Given this list of marker genes AP4E1, SYT2, LSM12, SCYL1, RPGR, ARHGAP26, PNKD, OPRL1, TSPAN11, SLC31A1, M1AP, NCL, ADCY1, SLCO3A1, KCNJ5, STARD3, SRRM1, DLGAP1, HTT, HIBADH, BCL2L2, DGKG, ASXL1 (NCBI Gene Id 23393), SDC2, GDI2, MAGED1, ACTR1B, TRIM66, DIXDC1, CPT1A, FGF1, ADAM12, CLBA1, CYP2C18, PIP4K2B, EPB41, SHMT2, NXPE4, SPTBN4, FOXA1, GOLGA7, KCNA6, TNS1, CDK6, GIT1 (NCBI Gene Id 28964, GIT ArfGAP 1), WDR37 (NCBI Gene Id 22884), ANKRD11, LRRC59, SCN8A, PRKG2, ITPR1, SEC24C, DERL2, MYO5A, TNIP1, MTUS1, SOAT1, PCBP3, ZHX3 (zinc fingers and homeoboxes 3), MIER2, GMEB2, C4orf19, DLG3, ATXN7, MED13L, CLASP1, ZSWIM6, ARC, EPHB2, ASB7, RCBTB1, SEL1L, WDR20, PUM1, MOBP, ATRN, HOXA2, SHCBP1, EPB41L3, WDR93, CMPK2, IQSEC1, H2AC8, HIPK4, PDE8A (phosphodiesterase 8A), MCL1, CAB39L, ATAD1, ITPKC, MYO5C, RAB27A, NECAP1, SAP30L, STEAP3 (STEAP3 metalloreductase), HM13, FOXC1, PLIN1, SLC9A8, E2F4, ISY1-RAB43, YIPF6, PHTF2, CCDC6, H2BC21, LIFR, AFAP1L2, TAS1R3, AKAP12, POTEG, RAB43, HMGA2, POT1, VPS45, GTF2I, STARD7, IKZF4, POTEH, BMAL1, CDK20, HMGCR, AKAP3, FAM72B, CYB5B, CLCN5, TOMM40L, SYS1, C6orf89, LPP, PSMF1, here is a description of the gene set: from publication Chen Y, Wang X (PMID 31504780) Human Gene Set: MIR760 studied in species Homo sapiens Genes predicted to be targets of miRBase v22 microRNA hsa-miR-760 in miRDB v6.0 with MirTarget v4 prediction scores > 80 (high confidence targets).